Given this list of marker genes Irgm1, Tcn2, Clec2d, Wnk3, Usp9x, Adam12, Enpp1, Heatr6, Cib2, Rbm47, Nrxn1, Btg1, Parp12 (poly (ADP-ribose) polymerase family, member 12), Nus1, Col11a1, Ranbp2, Cd79b, 4933407K13Rik, Crlf1, Xist, Omd, Galnt12, Zfp385b, Prokr1 (prokineticin receptor 1), Dnajc12, Ppp1r3c (protein phosphatase 1, regulatory subunit 3C), Gabra6, Runx3, here is a description of the gene set: Mouse Gene Set: GAUSSMANN_MLL_AF4_FUSION_TARGETS_B_UP Up-regulated genes from the set B (Fig. 5a): specific signature shared by cells expressing either AF4-MLL or MLL-AF4 fusion proteins. species: Mus musculus The reciprocal chromosomal translocation t(4;11) is correlated with infant, childhood, adult and therapy-related high-risk acute leukemia. Here, we investigated the biological effects of MLL.AF4, AF4.MLL or the combination of both reciprocal fusion proteins in a conditional in vitro cell culture model system. Several parameters like cell growth, cell cycling capacity, apoptotic behavior and growth transformation were investigated under physiological and stress conditions. Co-transfected cells displayed the highest resistance against apoptotic triggers, cell cycling capacity and loss-of-contact inhibition. These analyses were complemented by gene expression profiling experiments and specific gene signatures were established for each of the three cell lines. Interestingly, co-transfected cells strongly upregulate the homeobox gene Nanog. In combination with Oct4, the Nanog homeoprotein is steering maintenance of pluripotency and self-renewal in embryonic stem cells. Transcription of Nanog and other stem cell factors, like Oct4 and Bmi1, was verified in biopsy material of t(4;11) patient cells which express both reciprocal t(4;11) fusion genes. In conclusion, the presence of both reciprocal MLL fusion proteins confers biological properties known from t(4;11) leukemia, suggesting that each of the two fusion proteins contribute specific properties and, in combination, also synergistic effects to the leukemic phenotype. from publication Gaussmann A, Wenger T, Eberle I, Bursen A, Bracharz S, Herr I, Dingermann T, Marschalek R (PMID 17130830)